The following is a description of a gene set: Human Gene Set: GSE22589_HEALTHY_VS_HIV_INFECTED_DC_UP from publication Manel N, Hogstad B, Wang Y, Levy DE, Unutmaz D, Littman DR (PMID 20829794) Dendritic cells (DC) serve a key function in host defense, linking innate detection of microbes to the activation of pathogen-specific adaptive immune responses. Whether there is cell-intrinsic recognition of HIV-1 by host innate pattern-recognition receptors and subsequent coupling to antiviral T cell responses is not yet known. DC are largely resistant to infection with HIV-1, but facilitate infection of co-cultured T-helper cells through a process of trans-enhancement. We show here that, when DC resistance to infection is circumvented, HIV-1 induces DC maturation, an antiviral type I interferon response and activation of T cells. This innate response is dependent on the interaction of newly-synthesized HIV-1 capsid (CA) with cellular cyclophilin A (CypA) and the subsequent activation of the transcription factor IRF3. Because the peptidyl-prolyl isomerase CypA also interacts with CA to promote HIV-1 infectivity, our results suggest that CA conformation has evolved under opposing selective pressures for infectivity versus furtiveness. Thus, a cell intrinsic sensor for HIV-1 exists in DC and mediates an antiviral immune response, but it is not typically engaged due to absence of DC infection. The virulence of HIV-1 may be related to evasion of this response, whose manipulation may be necessary to generate an effective HIV-1 vaccine. Genes up-regulated in monocyte-derived dendritic cells: control versus HIV infection. species: Homo sapiens, and this is the list of marker genes: ETV5, PSPC1, SERBP1, CAMSAP2, ACOT11, TAF3, ZNF454, TCF12, UTP4, ATMIN (ATM interactor), CTPS1, ZYG11B, MTMR10, ORC6, ZRANB3, SCYL1, PA2G4, CSTF1, MEPCE, ING5, GLRX5, ZNF266, ECSIT, UCHL5, TARDBP, ZXDC, KDM2B, NOP56, PHETA2, INSR, RAD17, SETD1A, RRP15, CES3, PELP1, MARCHF6, ESF1, PRMT3, TFDP2, PRKCB, ZNF655, METTL1, PDP1, BAHD1, HAS3, TRMT61A, NELFB, ISG20L2, UBP1, SMC1A, FUCA2, RPL13, FAM98A (NCBI Gene Id 25940), C19orf48P, EIF3G, NFIC, TEX30 (NCBI Gene Id 93081), SMIM15, SVIP, POLR2D, CCDC117, TYSND1, KCTD20, SPRED2 (sprouty related EVH1 domain containing 2), CLUAP1, ANAPC15, THBS1, BDH1, DYNC1LI2, SLC11A1, PAFAH2, TXNRD2, ARMC1, SLC25A36, DIMT1, CAMK1D, IRF4, LARS2, MAT2A, PPRC1, COX10, G3BP1, TIMM9, ERRFI1, TCP1, TMEM126A, SMYD4, PIGY, HNRNPH2, STT3B, RIOK1, ADAM8, MTAP, USPL1, COIL, PPWD1, RMND5B, MAK16, PPIL4 (NCBI Gene Id 92943), CHST11, PDCD6IP, SNRPD2, HEATR3 (HEAT repeat containing 3), FXR2, SYS1, PRMT7, C2CD5, ZNF14, ZNF569, TIMM21, CLUH, DNAJC2, RRP9, ECHDC1, IPO11, TM6SF1, METTL24, RAB14, SLC36A4, P4HB, ZDHHC13, HAUS3, KCNAB2, VSTM2A, ENTPD5, ATP6V0E2, ITPR3, YRDC, SIKE1, DLGAP2, ROBO2, HIPK1, TCTA, WDR12, NGLY1, MAST3, NAP1L1, NDUFB8, HNRNPA1, TTLL4, YARS1, UBA2, PIGN, USP37, KAT14, PAK1IP1, HNRNPR, MEGF9, FASTKD5, CCT4, TRUB1, SLC25A30, PIGX, SPTSSA, HACD1, PTCD3 (NCBI Gene Id 55037), DUS1L, ADGRG3, MAPRE1, MINDY1, IPO4, PINX1, COG5, GAR1, MDC1, MRPS2, TUBGCP2, GTPBP4, POLR2H, SLC16A1, SMIM7, DPP3, TASP1, SETD6, RRS1, PSMD6, CDC42SE1, SGF29, PRKAB1, WTAP, RPL10, PRPF19, CIAO3, TTL, ITFG1, TMEM62, ZFAND4, RNF150, SLC25A13, PITPNB, ZNF229, DEPTOR (DEP domain containing MTOR interacting protein), TNFRSF9, TAF5L, SH3BP5L, CELSR3, BAG2, METTL3, BAG4, CDC14B